Given this list of marker genes Cgrrf1, Ang2, Tgfb1, Ppan, Trim46, Ceacam1, Osgin1, Rnd2, Lmx1a, Arhgap4, Macf1, Cst5, Hamp, Cpne6, Pot1b, Pafah1b1, Parp2, Slc25a33, Epb41l5, Adnp, Rtn4, Sertad1, G6pd2, Prkn, Adam17, Kdm2b, Cdkn2a, Zeb2, Hdac6, Sema4f, Lpar3, Egfr, Mir467a-5, Usp9x, Fbp1, Gdf2, Postn, Ncoa3, Llph, Flrt3, Ndufs3, Dnajb2, Nubp1, Slit1, Dact3, Hsd3b7, Ccdc85b, Gdf9, Nkx6-1, Reg1 (regenerating islet-derived 1), Il3, Ntn1, Cd44, Wnt5a, Trpv2, Wt1, Myl2, Sema3f, Raph1, Cdkl3, Npm1, Plxna1, Tgfbr1, Zfyve27, Ndufs6, Eif4g1, Syt3, Adam10, Ctnnb1, Hyal1, Rpl4, Pdlim5, Sema6c, Sema3a, Sox17 (NCBI Gene Id 20671), Pi16, Tro, Hrg, Slc23a2, Nrn1, Hdgfl2 (HDGF like 2), Cth, Fn1 (fibronectin 1), Fam107a, Nme6, Trip10, Prr5, Rims1, Nlgn3, Impact, Slc9a6, Fubp1, Sorbs2, Flrt1, Uts2r, Prickle1, Edn3, Nfix, Syt1, Vegfa, Dnm2, Apoe, Ptprj, Sirt6, Igfbp1, Abcc1, Cpne5, App, Itgb1, Ntrk3, Rgma, Edn2, Inhba, D130043K22Rik, Igfbp4, Pabir1, Crkl, Tgfbr2, Aurka, Ostn, Sertad2, Ssna1, Mir467a-10, Cdh1, Ip6k2, Nr3c1, Adam15, Dnph1, Shbg, Vcl, Alcam, Adcy10, Tnr, Smad4, Kif14, Bdkrb1, Wfdc1, Enpp1 (NCBI Gene Id 97628), Nanos1, Atg16l1, Mir467a-4, Serpine2 (serine (or cysteine) peptidase inhibitor, clade E, member 2), Cdkl5 (NCBI Gene Id 382253), Lamtor1, Agt, Phb1, Fhl1, Cyba, Pttg1, St8sia2, Lgi1, Slc9a1, Gdi1, Tead1, Nf2, Rb1, Cobl, Gsk3b, Meaf6, Wnt3a, Eaf2, Syt2, Tnn, Lhx2 (LIM homeobox protein 2), Sema6d, Prkcz, Trp53, Emx1, Msx1, Mir467a-9, Mmp14, Dnajc2, Gas1, Arhgap32, S100b, Limk1, Bin3, Mex3c, Abl1, Eif2b2, Npr2 (NCBI Gene Id 230103), Dscam, Ccn4, Slc39a12, Rims2, Kat7, Agtr2, Ext1, Commd5, Bcan, Crabp2, Mir467a-7, Tmem196 (transmembrane protein 196), Sphk2, Slit3, Mir467a-1, Exosc4, Mndal, Cirbp, Ifrd1, Pou4f2, Zc3h12d, Brca1, Edn1, Nrp1, Wnt11, Acsl4, Rnf157, Adipor2, Gng4, Olfm1, Mir467a-6, Rasal1, Cntf, Ulk1 (NCBI Gene Id 22241), Ros1, Barhl2, Rhoa, Smad3, Cib1, Myo5b (NCBI Gene Id 383414), Ppara, Tgfb2, Sfn, Kazald1, Tiam1, Ino80, Rack1, Afdn (afadin, adherens junction formation factor), N6amt1, Cda, Tchp, Hamp2, Syt4, Sh3glb1, Map2k5, Cttn, Jade2, Dyrk1a, Zfp639, Crlf3, C9orf72, Nanog, Pin1rt1, Jade3, Gsk3a, Trim40, Rerg, Mir467a-3, Akap13, Mapkap1, Cdkn2aip, Naif1, Exosc9, Csf2rb, Map2k4, Dcx, Dclk1, Sec61a1, Mir155, Draxin, Shtn1, Cpne9, Ppp1r9b, Prkg1, Clasp2, Sh3gl2, Lamtor2, Csnk2a1 (casein kinase 2, alpha 1 polypeptide), Ccn5, Ptprs, Adra1a, Cdkn1a, Ttc3, Map2, Sphk1, Ceacam2, Pin1, Psmd10, Bcl6, Iqgap1, Ccn3, Cd38 (CD38 antigen), Ngf, Rbm10, Fgf13, Psrc1, Pak1, Wdr36, L1cam, Adipor1, Bbc3, Cadm1, Ahsg, Mtpn, Spag6, Slitrk1, Sema7a, Igf1, Krt17, Ccr5, Mt3, Hnf4a, Cdc42, Ddr1, Cdkn1b, Plxna4, Lrp1, Bmpr2, Cdkn2d, Kmt2d, Igfbpl1, Rtn4r, Zmat3, Bst2, Il9r, Actr3, Pou4f3, Avp, Foxk1, Foxp1, Efna5, Sin3a, Hspa1b, Tnfrsf12a, Meis1, Supv3l1, Sesn1, Filip1l, Twf2, Mir21a, Nrn1l, Adra1b, H3f5, Eno1, Nfkbiz, Auts2, Lamb2, Caprin2, Omg, Rbbp7, Tspyl2, Hbegf, Ep300, Pparg, Xbp1, Plxna3, Csf1r, Zfp418, Ucn, Srf, Yap1, Syt17, Spg21, Igfbp3, Ddx39b, Rrad, Dcaf13, Clstn3, Cyfip1, Extl3, Dcstamp, Ccar2, Sh3bp4, P3h1, Sema5a, Rab21 (NCBI Gene Id 216344), Itga4, Fstl4, Bcl2 (B cell leukemia/lymphoma 2), Megf8, Sirt1, Hspa1a, Mir467a-8, Sgk1, Cdh4, Mag, Trim32, Igfbp5, Adrb1, Derl2, Dcun1d5, Cacng7, Rufy3, Gja1, Nppa, F2, Tnc, Tmem108, Sfrp2, Pten, Smad7, Ndel1, Pak6, Flt4, Rarg, Epm2a, Hnrnpk, Ptch2, Rnf6, Ddx49, Prdm11, Smo, Smarca2, Igfbp7, Cpne1, Mecp2, Osgin2, Tomm70a, Slc44a4, Ryk, Acvrl1, Tnk1, Cryaa, Armc12, Plaa, Sesn2, Mir467a-2, Cfl1, Il9, Ndn, Ppt1, G6pdx, Nppb, Septin7, Cdc73, Mtor, Anapc2, Smarca4, Plaat1, Ttl, Bltp1, Ist1, Sema5b, Mir124a-2, Ddx3x, Acvr1b, Usp47, Bdnf, Stk11, Cdhr2, Spart, Pum2, Bmp10, Clstn1, Klhl22, Robo1, Prdm4, Fxn, Wnt3, Arih2, Ncbp1, Dip2b (NCBI Gene Id 239667), Unc13a, Pml, Nin, D7Ertd443e, Islr2, Ptk2, Rictor, Rptor, Eif2ak4, Slc25a4, Bap1, Spg11 (SPG11, spatacsin vesicle trafficking associated), Ing4, Cav3, St7l, Creb3 (cAMP responsive element binding protein 3), Golga4 (NCBI Gene Id 54214), Mapt, Cryab (NCBI Gene Id 12955), Akap6, Dvl1, Dbn1, Ing5, Slit2, Dcbld2, Garem2, Hpn, Spag6l, Wasf1, Mlst8, Brat1, Kdm1a, D1Pas1, Kif26a, Myocd, Cxcr4, Eif4g2, Cyp27b1, Mad2l2, Map1b (NCBI Gene Id 268696), Mfsd2a, Uri1, Erbb2, Sox9, Ptk2b (PTK2 protein tyrosine kinase 2 beta), Ulk2, Sema4d, Yy1, Spag9, Eno1b, Cxcl16, Sertad3, Ppard, Cdk5, Picalm, Cep43, Jade1, Minar1, Nedd4l, Fdps, Ilk, Avpr1a, Col14a1, Rgs4, Gata4, Dcun1d3, Cd2ap, Tsg101, Sema3g, Ndufa13, Prmt2, Exosc2, Mcemp1, Mgll, Vgll4, Smurf1, Trpc5, Dab2ip, Dbnl, Crk, Mul1, Bcl11a, Ctdp1, Dab2, Rgs2, Ei24 (NCBI Gene Id 13663), Nrp2, Cxcl12, Sfrp1, Frzb, Sdcbp (NCBI Gene Id 53378), Nrg1, Hyal2, Atad3a, Sbf1, Itsn2, Tsc22d4, Cdkn2c, Mir124a-1 (microRNA 124a-1), Grem1, Taf9b, Epha7, Akt1, Map3k13, Ednra, Disc1, Cgref1, Cyfip2, Camk2d, here is a description of the gene set: studied in species Mus musculus The process in which a cell irreversibly increases in size over time by accretion and biosynthetic production of matter similar to that already present. Mouse Gene Set: GOBP_CELL_GROWTH